Given this list of marker genes KANSL1, STXBP1, STEEP1, TAF1, EBF3, SRRM2 (serine/arginine repetitive matrix 2), DYRK1A, CTCF, LMX1B, WAC, SLC12A2, here is a description of the gene set: Human Gene Set: HP_BROAD_CHIN studied in species Homo sapiens Increased width of the midpoint of the mandible (mental protuberance) and overlying soft tissue. Broad chin